Given this list of marker genes TBK1 (TANK binding kinase 1), HNRNPA2B1, HERC2, SEMA3A, RREB1, SIL1, NEU1, IRF6, SAMHD1, IDS, GNRHR, KISS1R, EIF2AK2, NHLH2, FLNA, NPAP1, TGFBR2, SUZ12, GTF2E2, FOXE1, DLK1, BUD23, TGM6, SMS, PRPH, SNRPN, TRH, BAG3, LTBP4, GFAP, DLX4, DLG1, PROKR2, MUSK, POU1F1, FLII, SELENON, VPS13B, ACAN, POLR1A, NSD1, CHRND, VPS11, AMER1 (NCBI Gene Id 160176), PI4KA, DYNC1I2, KIF1B, TUBB6, NSUN2, GPC3, NONO, DGCR6, KRT16, LONP1, CTNND2, LEMD3, ATG7, AOPEP (NCBI Gene Id 84909), IFIH1, GDAP1, APOA1, NOTCH3, PQBP1, UBQLN2, VHL, SNRPB, CAPN15, LYRM4, DLEC1, FKBP6, EXOSC9, SLC18A2, RNF113A, MYPN, MID1, ECM1 (extracellular matrix protein 1), CARS1, SHQ1, METTL27, TWNK, ELN, SOD1, MSX1, EMD, NEFH, MPLKIP, CYP27A1, RRM2B, NF1, SDHA, PWRN1, IQSEC2, GLT8D1, DGCR8, LAMB2 (NCBI Gene Id 3913), EPAS1 (NCBI Gene Id 2034), PRX, SLC25A11, RNF6, FLRT3, FRRS1L, REV3L, THAP1, RARS1, MEG3, RAPSN (NCBI Gene Id 85713), ANXA11 (NCBI Gene Id 311), CFAP410, SIM1, WDR11 (WD repeat domain 11), GRIN2A, TSHB, UBB, PROK2, IFT56, SPTBN1, CADM3 (NCBI Gene Id 57863), OPA1, FBN1, TRPV4, JAG1, ALDH4A1, ITGA7, ACTA1, PEX19, KMT2B, SH3BP2, LZTR1, NSMF, SNORD116-1, SLC5A7, FKRP, ATXN3, EIF4H, GNAL, LRP12, ABCB7, COQ6, DKK1, SEMA5A, TACR3, SNORD115-1, GP1BB, NDUFS8, CNOT2, IL17RD, CDH1, COL9A1, ADGRG1, SMARCB1, JMJD1C, LIFR, MATR3, RIC1, ARHGAP29, KRT14, SLC18A3, TONSL, PTPN11, NOTCH2, SLC3A1, PNPO, TMEM127, RNASEH2A, PREPL, CAMKMT, CHD7, GIPC1, CHRNA1, DGCR2, SCN4A, TP63, CDC73, ATXN2, TAC3, ERCC3, COL13A1, NOTCH2NLC, NCF1, B4GALNT1, ADH1C, SYNE2, PPP3CA, AIP, UPF3B, GNAS, ATP1A3, ALDH18A1, FKTN, TRHR, CCNF, SLC52A3, TMEM270, IGHMBP2, PON3, GABRG2, ATP5MC3 (ATP synthase membrane subunit c locus 3), LAMA3, MYOT, FH, KANSL1, GNPTAB, GMPPA, CLIP2, DCC, GALT, GRHL3, TRAPPC11, BMP4, GMPPB, COLQ, PPM1B, DDRGK1, PODXL, SNCAIP, ASAH1, GTF2IRD2, AAAS, MT-TT, HRAS, VARS1, RNASEH1, SLC2A3, WWOX, PPARGC1A (NCBI Gene Id 10891), CAMTA1, FTO, PIGN, KCNK9, AFF2, C1R, DUSP6, HSPG2, FUS, LIMK1, ABAT, SYNJ1, TRIM2, TK2, NLRP3, PWAR1, FOXP2, PANK2, ARHGEF38, LTBP3, HIRA, BAZ1B (NCBI Gene Id 9031), DNAJB2, HNRNPA1, TOR1A, MLXIPL, GNAI3, ZFYVE26, OCA2, COQ2, COL6A3, CRLF1, PPP1R21, PHF8, SYNE1, MEGF10, FTL, MGP, LAMA2, EZH2, LIG4, SEC24C, TBC1D2B, SET, PON2, SLC26A4, GBA1, PCNT, ALPL, MPV17, MYH14, THRA (NCBI Gene Id 7067), TMEM43, KRT5, SPART, CRYAB, TNNC2, TBL2, DNMT3A, TPM3, FGF17, DST, KDM6A, CAMK2B, STX1A, RNU7-1 (RNA, U7 small nuclear 1), TARS1, CRTAP, EDA, SHOC2, VPS37D (NCBI Gene Id 171020), MAGEL2, DNAJC6, HK1 (NCBI Gene Id 59333), TBX1, EIF4A3, SDHC, RAF1, CHCHD10, PYROXD1, PLXND1, UBA1, PABPN1, FGFR1, ZBTB18 (zinc finger and BTB domain containing 18), MYH3, MED12, UNC13A (NCBI Gene Id 23025), DGUOK, TUBB4A, SPRY4, DLST, MAPK1, NLRP1, VAPB, CHMP2B, SQSTM1, ADCY6, PLEC, STX16, LSM11 (LSM11, U7 small nuclear RNA associated), HESX1, TAF15, SRCAP, POMT1, FHL1, SEC31A, SDHB, ASPA, ALS2, COBLL1, ATRX, ZNF699, SRPX2, CCDC141, SH3TC2, FOXP1, CHAT, ATP6V0A2, SPG7, ERI1, TRAPPC12, KRT6B, NALCN, TTC19, NF2, MKRN3, TFAP2A, HACD1, LAMB3, NDN, TLK2, MYMX, GPR101, MAPT, NKX2-1, COMT, GTF2IRD1, PMP22, DCTN1, POLA1, POLG, AR, MGME1, MYO9A, NIPBL, GLE1, POMGNT1, RYR1, ZDHHC9, WRN, HAAO, TSHR, LARGE1, RNASEH2C, SETBP1, SRD5A2, TTN, NDNF, SLC25A1, SPEG, SOX10, GARS1, ANG, NFE2L2, TSPYL1, PRKRA, SLC26A2, MECP2, PLIN4, KCTD17, SH2B1, ATP6AP2, KMT2D, MYCN, NECTIN1, STAG2, VCP, ACTB, PDGFRA, AGRN, UFD1, TREM2, POMT2, MDH2, TBP, NR4A2, LMNA (lamin A/C), VPS13A, RET, DEAF1, OPTN, RNASEH2B (NCBI Gene Id 79621), SLC19A2, NKX2-5, SEC24D, SCO2, SYT2, PFN1, OCRL, DUOX2, MYL2, ATP5F1A, PON1, SDHAF2, ARVCF, GPC4, RILPL1, CHRNE, HS6ST1, FEZF1, MAX, BIN1, TPK1, UNC45B, SBF2, ERBB4, ADAR, HTT, AGA, ARID1B, SNAP25, TPM2, NEK1, CEP104, PLCB4, SERPING1, DNAJC30, AARS1, GNE, P4HB, IL1RAPL1 (NCBI Gene Id 4399), RTL1, CRPPA, KRT6A, DAO, GNRH1, MFN2, LAMC2, SDHD, TSPOAP1, RAI1, FXN, VAMP1, TRIM37, COQ9, ATXN8OS, FGF8, TRIP4, GTF2H5, GTF2I, ERCC2, TREX1, ESS2, GGPS1, HMBS, HTRA1, TARDBP, PAX8, KISS1, SMAD4, BRAF, MAP3K20, NUS1, ANOS1, B3GALNT2, KRT17, CIZ1, FIG4, RFC2, GFPT1, here is a description of the gene set: Human Gene Set: HP_ABNORMALITY_OF_THE_VOICE Abnormality of the voice species: Homo sapiens